The following is a description of a gene set: A membrane-bounded intracellular vesicle as initially formed upon the ingestion of particulate material by phagocytosis. Human Gene Set: GOCC_EARLY_PHAGOSOME species: Homo sapiens, and this is the list of marker genes: SLC9A9, APPL2, RAB5A, SYK, RAB31, SYT11, UNC93B1, TLR9, MTMR4, SYT7, APPL1, SNX3, PLA2G5, TLR7